The following is a description of a gene set: Genes in the cancer module 153. studied in species Homo sapiens Human Gene Set: MODULE_153, and this is the list of marker genes: COL7A1, KRT1, GJB5, COL1A1, PLOD1, PROX1, CCN2, HOXB13, DSP, SCEL, LCE2B, S100A7 (S100 calcium binding protein A7), EDA, SPRR1B, ATP2C1, KRT16, KRT17, KRT14, SNAI2 (NCBI Gene Id 6591), KRT5, LAMB3, KRT6A, KRT15, EVPL, WAS, CRABP2, LAMC2, ALDH3A2, LAMA3, FABP5, TFAP2A, KRT6B, KRT13, EMP1